The following is a description of a gene set: species: Mus musculus Cluster 1: genes progressively down-regulated over 24 h (peak at 0 h timepoint) during differentiation of 3T3-L1 fibroblasts into adipocytes in response to adipogenic hormones. The molecular mechanisms that regulate cellular differentiation during development and throughout life are complex. It is now recognized that precise patterns of differentially expressed genes ultimately direct a particular cell toward a given lineage and many of these are regulated during the earliest stages of differentiation. Using a microarray-based expression analysis, we have examined gene expression profiles during the first 24 h of 3T3-L1 adipocyte differentiation. RNA was isolated at times 0, 2, 8, 16, and 24 h following stimulation of differentiation and hybridized in duplicate to high density Affymetrix microarray gene chips containing a series of 13,179 cDNA/expressed sequence tag (EST) probe sets. Two hundred and eighty-five cDNA/ESTs were shown to have at least a fivefold change in expression levels during this time course and both hierarchical and self-organizing map clustering analysis was performed to categorize them by expression profiles. Several genes known to be regulated during this time period were confirmed and Western blot analysis of the proteins encoded by some of the identified genes revealed expression profiles similar to their mRNA counterparts. As expected, many of the genes identified have not been examined in such a critical time period during adipogenesis and may well represent novel adipogenic mediators. from publication Burton GR, Guan Y, Nagarajan R, McGehee RE Jr (PMID 12137940) Human Gene Set: BURTON_ADIPOGENESIS_PEAK_AT_0HR, and this is the list of marker genes: RALGDS, PCK2, RUNX1T1, PDGFRA, CALML4, GAS2, MAP4, MYL9, PLAT, CSF1, IL11RA, LPL, SORD, CCN3, PDGFRB, MXD4 (MAX dimerization protein 4), GAS1, APBB1IP, FAH, ASAP1, CRYAB, PCCB, SPP1, SERF2, TGFB3, ISG15, DAB2, F3, DDIT3, NREP, SERPINB9, CTSK, RAB11FIP5, COL8A1, THBS2, PLIN2, ADH1A, IDH1 (isocitrate dehydrogenase (NADP(+)) 1), SFRP2, OGN (NCBI Gene Id 4969), TIMP3 (TIMP metallopeptidase inhibitor 3), MARCKS, VEGFD, NAA10, FLOT1, COL11A1, CCL15, TPM1, KLF2, GADD45A, NEAT1, FZD2, CCNG2, TLN1, VEGFC, PSMB10, MGP, CYB5R1, TLE5, RASL11B, ACTA2, IGF1, TRIB3